The following is a description of a gene set: studied in species Mus musculus GRB2:SOS provides linkage to MAPK signaling for Integrins Mouse Gene Set: REACTOME_GRB2_SOS_PROVIDES_LINKAGE_TO_MAPK_SIGNALING_FOR_INTEGRINS, and this is the list of marker genes: Fgb, Vwf, Grb2, Itgb3, Rap1a, Tln1, Ptk2, Fn1, Fga, Src, Sos1, Rap1b, Fgg, Itga2b, Apbb1ip